Given this list of marker genes CAV1, IFT122, SLC12A3, CSF1R (colony stimulating factor 1 receptor), CAMKMT, GNAS, DGCR8, CLCNKB, CA2, UFD1, FAT4, HLA-DQA1, MT-CO1, ACADVL (NCBI Gene Id 37), GP1BB, VDR, MIR140, LPIN1, TNFSF11, SNX10, GNA11, MT-CO3 (NCBI Gene Id 4514), BTK, COMT, RREB1, CACNA1C, RRAGD, GEMIN4, GATA3, SEC24C, DMP1, CYP2R1, ADAMTS3, TBCE, TNFRSF11A, RMRP, OBSCN, CCBE1, ESS2, PLVAP, ALG12, PPM1B, FOXN1, CLDN16, IVD, CLCN7, FAM111A, AIRE, CASR, STX16, RFX7, ARVCF, FOXP3, JMJD1C, UBR1, SLC4A1, SLC3A1, HADHB, GCM2, OSTM1, DGCR6, PREPL, CTNS, PIK3C2A, TCIRG1, PTH, CHD7, CYP27B1, ORAI1, FOCAD, HLA-DQB1, TRPM6, HADHA, IL36RN, USP53, ENPP1, CYP3A4, DGCR2, FARSB, GNB2, HIRA, GNAS-AS1, PLEKHM1, TBX1, FGF23, AP1S3, RYR1, here is a description of the gene set: Human Gene Set: HP_HYPOCALCEMIA An abnormally decreased calcium concentration in the blood. studied in species Homo sapiens Hypocalcemia